The following is a description of a gene set: Cytokines mediate cell-cell communication in the immune system and represent important therapeutic targets. A myriad of studies have highlighted their central role in immune function, yet we lack a global view of the cellular responses of each immune cell type to each cytokine. To address this gap, the authors created the Immune Dictionary, a compendium of single-cell transcriptomic profiles of more than 17 immune cell types in response to each of 86 cytokines (>1,400 cytokine-cell type combinations) in mouse lymph nodes in vivo. A cytokine-centric view of the dictionary revealed that most cytokines induce highly cell-type-specific responses. For example, the inflammatory cytokine interleukin-1β induces distinct gene programmes in almost every cell type. A cell-type-centric view of the dictionary identified more than 66 cytokine-driven cellular polarization states across immune cell types, including previously uncharacterized states such as an interleukin-18-induced polyfunctional natural killer cell state. Genes positively differentially expressed in cell type: pDC (plasmacytoid dendritic cell) upon treatment with cytokine: CD40L in mouse lymph nodes in vivo. species: Mus musculus Mouse Gene Set: CUI_PDC_CD40L_RESPONSE_UP from publication Cui A, Huang T, Li S, Ma A, Pérez JL, Sander C, Keskin DB, Wu CJ, Fraenkel E, Hacohen N (PMID 38057668), and this is the list of marker genes: Map2k3, Rnps1, Got1, Trmt10a, Nae1, H2-Aa, Stx17, Cdk14, Gna12, P4ha1, Sf3b4, Herpud2